Given this list of marker genes MCOLN1, TRPV1, RAB11B, KCNK18, SCNN1G, SERPINF1, KCNK4, SLC9A1, CTSS, P2RX5, KCNK1, GPR68, INSRR, HYAL1, SCNN1A, RAB11FIP5, PKD1L3, KCNK3, GPR151, SCNN1B, GPR65, ABCC8, CLCN7, KCNK9, GPLD1, PKD2L1, SCNN1D, ASIC1 (acid sensing ion channel subunit 1), ASIC3, GPR31, CHP1, ARSB, GBA1, GPR4, GNA11, ASIC2, ACER1, HVCN1, SST, LGMN, here is a description of the gene set: species: Homo sapiens Human Gene Set: GOBP_RESPONSE_TO_PH Any process that results in a change in state or activity of a cell or an organism (in terms of movement, secretion, enzyme production, gene expression, etc.) as a result of a pH stimulus. pH is a measure of the acidity or basicity of an aqueous solution.